The following is a description of a gene set: Tumor growth is associated with a profound alteration of myelopoiesis, leading to recruitment of immunosuppressive cells known as myeloid-derived suppressor cells (MDSCs). Analyzing the cytokines affecting myelo-monocytic differentiation produced by various experimental tumors, we found that GM-CSF, G-CSF, and IL-6 allowed a rapid generation of MDSCs from precursors present in mouse and human bone marrow (BM). BM-MDSCs induced by GM-CSF+IL-6 possessed the highest tolerogenic activity, as revealed by the ability to impair the priming of IFN- -producing CD8+ T cells upon in vivo adoptive transfer. Moreover, adoptive transfer of syngeneic, GM-CSF+IL-6-conditioned MDSCs to diabetic mice transplanted with allogeneic pancreatic islets resulted in long term acceptance of the allograft and correction of the diabetic status. Cytokines inducing MDSCs acted on a common molecular pathway. Immunoregulatory activity of both tumor-induced and BM-derived MDSCs was entirely dependent on C/EBP transcription factor, a key component of the emergency myelopoiesis triggered by stress and inflammation. Adoptive transfer of tumor antigen-specific CD8+ T lymphocytes resulted in therapy of established tumors only in mice lacking C/EBP in myeloid compartment. These data unveil another link between inflammation and cancer and identify a novel molecular target to control tumor-induced immune suppression. We used gene expression analysis to identify those factors, secreted by tumor-infiltrating MDSC, which could drive emathopoiesis. Moreover we compare gene expression profile of tumor-induced MDSC, obtained from either the spleen and the tumor infiltrate of tumor bearing mice, and in vitro bone marrow-derived MDSC. Genes down-regulated in CD11b+ cells from BALB/c mice bearing 4T1 mammary carcinoma: spleen of BALB/c mice: spleen versus tumor infiltrating monocytes. species: Homo sapiens from publication Marigo I, Bosio E, Solito S, Mesa C, Fernandez A, Dolcetti L, Ugel S, Sonda N, Bicciato S, Falisi E, Calabrese F, Basso G, Zanovello P, Cozzi E, Mandruzzato S, Bronte V (PMID 20605485) Human Gene Set: GSE21927_SPLEEN_VS_4T1_TUMOR_MONOCYTE_BALBC_DN, and this is the list of marker genes: RASEF, SNAI1, ABCB10, TIMM21, ANGEL1, SLC35F4, CLEC4G, CMTM4, DENND1B (DENN domain containing 1B), SCGN (secretagogin, EF-hand calcium binding protein), H2AC17, SLC5A6, CASP3, GPRC5D-AS1 (GPRC5D and HEBP1 antisense RNA 1), PSMG1, PPT1, PARP12, SSX2IP, XRCC5, LYSMD2, PSMC5, C8orf88, HNRNPD, PINX1, DDX41, EFTUD2, KCNH7, RANBP17, SLC25A48-AS1, MAML1, RBM19, TONSL, VWA3B, KCNRG, STX17, SNRPB, XPNPEP3, RITA1, NOP2, ACSL1, NOX3 (NADPH oxidase 3, NCBI Gene Id 57770), DHODH, CDK12, ELAC2, AFAP1, IMP3, DNAJC2, STEAP3, HELLS, DNAJC3, ATM, UBAC1, POLR2J, ARRDC4, SLCO4A1-AS1, UMAD1 (NCBI Gene Id 89979), GTSE1, ETFA, SNX5, SETD6, TMEM266, ENTR1, ENSA, MGLL, TWF1, ICAM3, ANGEL2, PRKDC, SSU72, PSG4, RABGGTB, PGBD5, SMARCD2, SLC35B3, BOC, NKX2-1 (NK2 homeobox 1), UBAP1L, KCNH2, VESTAR, DDX10, TBP, ATP2C1, NDC1, ACAT1, EXOSC3, CHSY1, KICS2, GPR143, GTF3C6, GTF2E1, CCDC117, ZC3H3, ID3, GFM2, NFYC-AS1, MITF, SRRT, HOTAIR, PAG1, TSN, FRMD4B, LINC00842, MRM1, RDH13, H4C5, PPP1CA, SLC16A7, CRY1, CCSER1, ETFB, XPO4, CCNB1, RSPO3 (R-spondin 3), UACA, BCAP29, TMPO-AS1, FOXL1 (NCBI Gene Id 2300), SCIN, PDZRN3, CARNMT1, GFM1, FAM107A, UBR7, FARSB, GART, SERBP1, NFATC3, ABCB6, SAP30, PSMG4, CEP152, PC (pyruvate carboxylase), FNBP4, NEMP1, NPC1, ADAMTS1, GNPNAT1, RPL11, ARHGEF28, GRPEL1 (GrpE like 1, mitochondrial), TMEM108, POLE2 (DNA polymerase epsilon 2, accessory subunit), COA6, ATP5MC1, PRDM16-DT, CENPE, PARP2 (poly(ADP-ribose) polymerase 2), FANCE, NUP37 (NCBI Gene Id 79023), COPRS, SBNO2, E2F8, CROT, EMC8, AIRIM, AKAP8, CHODL, MYBBP1A, BCS1L, MT2A, JDP2, RNF26, PSME3IP1, STYK1, PLEKHG7, SLC35A3, TPSD1, CDCA7L, FEN1, CGN, PRPF38B, SPINK6, RBM14, WASHC4, HS3ST3A1, MCMBP, IFI30, SUCLG2, TEX10, LINC02593, NDUFB6, AHSA1, SP2, ENOSF1, ARAF, TATDN2, MTFR2, RWDD1, NINJ1, SLC15A3, SFRP1, IQGAP1, CDCA8, MRRF, CCDC136, LIFR